Given this list of marker genes TMLHE, SMS, SUFU, SEC24C, BCAS3, VPS13B, TMEM94, UFD1 (ubiquitin recognition factor in ER associated degradation 1), TWIST2, SMARCA2, TRAPPC9, KIF26A, H4C11, KCNK9 (potassium two pore domain channel subfamily K member 9), CDC42, FIG4, WNT4, CPLX1, PPP2CA, IFT57, SMARCE1, CKAP2L, ZEB2, RNU4ATAC, ERLIN2, ROR2, SATB2, CNTNAP2, FLII, CLCN3, PSMD12, IQSEC2, TFAP2B, KIF7, WDR4, SHH, NELFA, PIGW (NCBI Gene Id 284098), ADAMTS3, KCNK4 (potassium two pore domain channel subfamily K member 4), ACBD6, TCF4, RNU4-2, JMJD1C, FBXO11, TBX1, MADD, RTL1, PUS7, PQBP1, MTX2, PIGL, TRRAP, RALA, AP4B1, CRIPTO, MEG3 (NCBI Gene Id 55384), HECTD4, NAA10, RREB1, DLL1, SOX11, PIGY, COL3A1, GRIA3, BCL11B, AP4M1, DVL3, PSMC3, LRP4, NOG, WLS, ZNF292, MCTP2, HDAC6, SMPD4, HIRA, POGZ, CTCF, CREBBP, NSRP1, CNOT3, MAN1B1, ASH1L, PRKACA, NXN, GRIA4, MAP3K7, PIGO, DPYSL5, OPHN1, SLC35A1, ITCH, CCBE1, GLI2, CUL4B, PCDHGC4 (protocadherin gamma subfamily C, 4), TRMT10A, GATAD2B, ALX4, VPS51, SHMT2 (serine hydroxymethyltransferase 2), FAT4, ZDHHC9, HIVEP2, CTBP1, HNRNPH2, MEF2C, GAS1, ARID1B, TMEM237, TBC1D20, STAG2, NKAP, CDON, AP4S1, SMC1A, ARID2, FZD2, SON, CCDC22, EXT2, ARVCF, FGFRL1, MED12, DHX37, TTC5, PHF21A, KCNH1, H4C5, ANKRD17, LARP7 (NCBI Gene Id 51574), FOXH1, DEAF1, SMAD4, PTCH1, VAC14, RAB18, LETM1, JARID2, MID2 (midline 2), ARID1A, HUWE1, GMPPA, CRELD1, TRIP12, PIGV, TALDO1, PPP3CA, DISP1, MED25, C1GALT1C1, BPTF, APC, SIN3A, WDR26, EMC1, RAB3GAP1, GP1BB, TCF3, TSPAN7, PITX2, TRIO, DVL1, NSD2, EIF4A2, ALG12, NFIX, SIX3, ZBTB18, PHIP, WNT5A, RAP1GDS1, KDM4B, TBR1, PGAP3, MED12L, MEIS2, TAOK1, UBE3B, UPF3B, AHDC1, FREM1, GNB1, AFF3, TRPM3, CHAMP1, RAI1, CDH2, BRPF1, ADAMTSL1, ERCC1, TWIST1, MAPK8IP3, KIDINS220, SMARCA4, SLC35A2, NONO, DENND5A, KAT6A, SPTBN1, TXNL4A, PDE4D, RAB3GAP2, STIM1, H4C9, ZIC2, FOXL2, RUNX2 (NCBI Gene Id 860), NALCN, CDH11 (NCBI Gene Id 1009), HOXB1, PIGG (NCBI Gene Id 54872), IREB2, AUTS2, KCNJ6, KDF1, SRCAP, PTH1R, PGAP2, TAF4, LRRC32, SETBP1, CDC42BPB, PPP1R15B (NCBI Gene Id 84919), DOCK7, CHD5, SPEN, UNC80, PARS2, AP4E1, COMT, NEXMIF (neurite extension and migration factor), TMEM70, EDEM3, WBP4, NSUN2, KIFBP, DPF2, NR4A2, TGIF1, RNF2, DLK1, NODAL, ALDH6A1, SH3PXD2B, FGFR1, EPB41L1 (NCBI Gene Id 23260), GALNT2, PRKACB, TNPO2, POLR3A, FGF8, CDK13, AP1S2 (adaptor related protein complex 1 subunit sigma 2), SCN4A (sodium voltage-gated channel alpha subunit 4), TCTN3, here is a description of the gene set: Short philtrum species: Homo sapiens Distance between nasal base and midline upper lip vermilion border more than 2 SD below the mean. Alternatively, an apparently decreased distance between nasal base and midline upper lip vermilion border. Human Gene Set: HP_SHORT_PHILTRUM